The following is a description of a gene set: studied in species Homo sapiens An assembly of actin filaments that are on the same axis but may be oriented with the same or opposite polarities and may be packed with different levels of tightness. Human Gene Set: GOCC_ACTIN_FILAMENT_BUNDLE, and this is the list of marker genes: ACTN1, TLNRD1, TPM3, PPP1R12B, TEK, PPP1R12A, SHROOM4, LDB3 (NCBI Gene Id 1219), RFLNA, PGM5, FAM107A (family with sequence similarity 107 member A), MYH14, ASB2, MYL9, SEPTIN7, ABLIM1, PDLIM5, PDLIM3, CALD1, PDLIM4, SIPA1L3, FERMT2, ZYX, PTK2, MST1R, SORBS1, BAG3, GAS2, DST, PXN, SPEF1, LIMA1, DIXDC1, MYH7, DIAPH3, MICALL2, FHOD1, CTTNBP2NL, TPM1, DCTN4, MYLK, SYNPO, SH2B2, CFL1, VANGL2, LIMCH1, VIL1, SEPTIN11, PDLIM2, PPP1R12C (protein phosphatase 1 regulatory subunit 12C), DAAM1, LUZP1, PRICKLE4, RFLNB, MYO1C, ACTA2, AFAP1, TPM4, CORO1B, ACTA1, SEPTIN12, NEBL, ROR1, CNN2, MYH10, AFAP1L1, MARCKS, MYL12B, PLS1, FHL3, CRYAB (crystallin alpha B), PALLD, ACTN4, SEPTIN9 (septin 9), PDLIM1 (NCBI Gene Id 9124), XIRP2, XIRP1, TRIP6, PLS3, GAS2L2, GAS2L1, FLNB, LCP1, FBLIM1, MYH9, CYBA, AMOT, EVL (Enah/Vasp-like), RAI14, MYH6, ABLIM3, LPP, PDLIM7, SYNPO2, BLOC1S6 (NCBI Gene Id 26258), FSCN1